The following is a description of a gene set: Human Gene Set: GOBP_MUSCLE_CELL_CELLULAR_HOMEOSTASIS studied in species Homo sapiens The cellular homeostatic process that preserves a muscle cell in a stable functional or structural state., and this is the list of marker genes: BAG3, CFL2, ALDOA, TRIM32, ANKH, DMD, MTM1 (myotubularin 1), SRF, MSTN, CSRP3, LOX, CAPN3, LARGE2, LARGE1, TGFB1, CHRNA1, PLG, PFKM, HIF1A, LAMP2, SGCZ, CAV1, GAA, PLN, FXN, SOD1